Given this list of marker genes MVK, HMGCS1, FDPS, PMVK, HMGCR, SMARCD3, PPARA, SP1, TBL1X, ACACB, IDI1, CYP51A1, LSS, TBL1XR1, TGS1 (trimethylguanosine synthase 1), MED1, MTF1, HELZ2, CREBBP, SC5D, NFYC, NCOA1, SQLE, MVD, NCOA2 (nuclear receptor coactivator 2), TM7SF2, RXRA, ELOVL6, NFYA, NFYB, CHD9, GPAM, GGPS1, SREBF1, ACACA (acetyl-CoA carboxylase alpha), SCD, DHCR7, SREBF2, FDFT1, NCOA6, FASN, CARM1, here is a description of the gene set: studied in species Homo sapiens Reactome Pathway: Activation of gene expression by SREBF (SREBP) After transiting to the nucleus SREBPs (SREBP1A/1C/2, SREBFs) bind short sequences, sterol regulatory elements (SREs), in the promoters of target genes. SREBPs alone are relatively weak activators of transcription, with SREBP1C being significantly weaker than SREBP1A or SREBP2. In combination with other transcription factors such as SP1 and NF-Y the SREBPs are much stronger activators. SREBP1C seems to more specifically target genes involved in fatty acid synthesis while SREBP2 seems to target genes involved in cholesterol synthesis. part of: Regulation of cholesterol biosynthesis by SREBP (SREBF)